The following is a description of a gene set: studied in species Homo sapiens Reactome Pathway: Abacavir metabolism part of: Abacavir ADME Abacavir activation proceeds steps of phosphorylation, deamination to yield carbovir monophosphate, and phosphorylation of the latter compound to yield the triphosphate. In addition, abacavir can be conjugated with glucuronide or oxidized to its 5'-carboxylate derivative, the two major forms in which it is excreted from the body., and this is the list of marker genes: MAPDA, NT5C2, ADH1A, PCK1